The following is a description of a gene set: Human Gene Set: GOMF_SUMO_TRANSFERASE_ACTIVITY Catalysis of the transfer of SUMO from one protein to another via the reaction X-SUMO + Y = Y-SUMO + X, where both X-SUMO and Y-SUMO are covalent linkages. studied in species Homo sapiens, and this is the list of marker genes: CDKN2A, HDAC4, TRIM28, RANBP2, ZBED1, ZMIZ1, MDM2, TRIM60, UHRF2, RNF212B, PIAS2, KIAA1586, TRIM27, EGR2, RNF212, CBX4, PML, TOPORS, PIAS3, NSMCE2, ZMIZ2, MUL1, HDAC7, ZNF451, PIAS1, UBE2I, SUMO2, PIAS4